Given this list of marker genes Itga2, Rbm25, Lpl, Znrf3, Tagap1, Cntfr, Vps13a, Plag1, Pip4p2, Spock3, Yaf2, Ccdc120, Zfp850, Tbx22, Neto1, Zbtb41, Syncrip, Zfp148, Extl2, Wtap, Cebpg, Nrbf2, Set, Strbp, Rasa2, Sh3rf1, Fhip1b, Cmtm8, Tmem196, Hopx, Rnf214, Itgb1, Lin9, Mef2d, Rnf144a, Srgap3, Rad21, Map7d2, Crybg3, Vkorc1l1, Skint9, A630023A22Rik, Wrap73, Slc4a7, Ppm1h, Epc2, Edil3, Gria3 (NCBI Gene Id 73036), Cstf3, Med14, Homer1, Cnbp, Rictor, Arl6ip6, Gm4884, Prickle1, Spry1, Cxcl16, Khdc4, Pira12 (paired-Ig-like receptor A12), Smo, Tab2, Ralgds, Gtf2b, Mrpl39, Dock11, Csmd2, Zfp36l2, Cacng5, Serpinb10, Sema3a, Gucy1a2, Lrrc7, Spag9, Rap1gap2, Lix1l, Zfp407, Lin52, Cacna1b, Ifit2, Zc3h12c, Tmem151a, Tcerg1l (transcription elongation regulator 1-like), Dmrta2, Fam76b, Stk24, Phrf1, Epb41l1, Tnfaip8, Irs1, Ano4, Epha7, Nectin3, Zfp30, Ttll7, Hoxd1, Kcnma1, Psd3, Milr1, Tubgcp5, Zfp608, Mtmr6, Myt1l, Rab11fip3, Clcn2, Eif5a2, Egln1, Marf1, Arid1b, Stard13, Prpf4b, Eml6, Alcam, Btbd3, Fosb, Srpk2, Gfod1, Fgd4, Asah1, Loxl3, Plxna2, Unk, Mex3c, Tada2b, Gabra1, Styx, Ctsc, Slc38a2, Cxcl5, Marchf7, Dleu7, Trhr, Golph3, B3galt2, Lrp8, Rgs4, Ube3c, Zfp704 (NCBI Gene Id 269407), Klf6, Nrf1, Elmod1, Adamts1, Ccdc68, Lztfl1, Itpr1, Aak1, Nxt2, U2surp, Xiap, Rab11b (NCBI Gene Id 320652), Arhgef7, Zfp451, 1700066M21Rik, Rev3l, Zfp521, Far1, Foxf2, Erf, Gm3604, Tbc1d22b, Gk, Golim4, Gm5114, Ankhd1, Eea1, Dlg2, Nefl, Fbxo34, Trim34a, Akap13, Zfp1008, Crebrf, Epha4, Ets1, Taok1 (TAO kinase 1), Dennd4a, Mex3b, Trhde, Cramp1, Prr12, Akap9, Olfml2b (olfactomedin-like 2B), Xpo7, Cask, Grsf1, Txlng, Hectd2, Arhgap29, Qrfprl, Pms1, Rnf38, Cul3, Ccnc, Zmym6, Fbxl17, Rab14, Gucy1b1, Rerg, Cilk1, Yy1, Ccar1, Arhgef33, Sh3gl3, Wdr43, Efnb2, Ssbp2, Usp42, Pde4dip, Runx2, Tshz3, Phf8, Mfsd1, Calu, Gpcpd1, Lrrc42, Cflar, Btg1 (BTG anti-proliferation factor 1), Fchsd2, Il1rap, Phf6, Schip1, Dip2b, Kmt2c, Mkrn2os, Arid4b, Adgrf5, Msx2, Lrp6, Hycc2, Zfp280d, Pcsk5, AI182371, Adgre4, Rsbn1, Fam210a, Ankrd1, Akain1, Tmc8, Herc6, Ccdc25, Mcu (mitochondrial calcium uniporter), Hmgxb4, Rnf4, Zwint, Zfp811, Rab7, Nr4a3 (NCBI Gene Id 18124), Il7, Heatr5b, Abcb1b, Fgf4, Dck, Pea15a, Mbd4, Anks1b, Arhgef10l, Eif4ebp1, Rb1cc1, Fli1, Zfyve16, Usp32, Zbtb44, Nek1, Tardbp, Dnttip2, Six6, Timp3, Otx2, Pmp22, Rgmb, Arl8a, Camsap2, Dcdc2a, Kbtbd7, Mapk1, Carmil1, Slc17a6, Pitx2, Mpzl1, Adamts17, Slc8a1, Lifr, Vcan, L1cam, Dnali1, Klhl14, Pum2, Kif2a, Tob1, Zbtb10, Nr3c2, Arfgef2, Ythdc2, Erg28, Pdik1l, Camk2d, Ndst3, Spred1, Zbtb11, Pira2, Fbxl5, Atad1, Bmper, Gpm6b, Usp25 (NCBI Gene Id 30940), Bdnf, Usp6nl, Serpinb9g, Evx2 (NCBI Gene Id 14029), Impg2, Csgalnact2, Chek2, Zrsr2, Sdcbp, Bdp1, Tmem215, Rsf1, Tceanc, Wdfy3, Zswim6, Sdad1, Tjp2 (NCBI Gene Id 226034), Sft2d3, Prr16, Tmtc2, Ddx10, Tmem68, Sfpq, Dlat, Cep135, Tm9sf3, Nfyb, Nom1, Med13, Dennd2b, Mrc1, Zmat1 (zinc finger, matrin type 1), Prkcd, Ptp4a3, Mphosph10, Rasef, Fbxo33, Col19a1, Nkrf, Rcn2 (NCBI Gene Id 27014), Ttc7, Dph6 (NCBI Gene Id 66632), Tnrc6c, Lamtor3, Spin1, Cdh9, Ino80d, Diaph2, Svil, Trim59, Septin9, Gm5592, Foxa1, St8sia4, Gm15881, Hhip, Zfp182, Lemd3, Itch, Rbfox1, Vps13d, Kif13a, Cfap20, Sh3gl2, Ddx21, Elovl5, Rad51d, Sox21, Ntrk2, Sim1, 1110059G10Rik, Myrf, Nlrp2 (NLR family, pyrin domain containing 2), Dync1li2 (dynein, cytoplasmic 1 light intermediate chain 2), Pafah1b1, Rngtt, Alg6, Grm5, Ppfia2, Rab11fip2, Nr1i2, Eif1ad (NCBI Gene Id 69860), Ckap2, Gata3, Zfp935, G2e3, Cav2, Sptbn1 (NCBI Gene Id 268394), Tagap, Mthfd1, Lats1, Glipr1l2, Hdac4, Clec12a, Casp8ap2 (caspase 8 associated protein 2), Akap6, Dcun1d4, Btaf1, Bmp3, Trpc1, Tmem41b, Bmp5, Mbnl2, Ptprr, Ptprb, Ube2b, Fgfr2, Tle1, Grpr, Nectin4, Hivep1, Ankrd13c, Tnfrsf11b, Cks2 (CDC28 protein kinase regulatory subunit 2), Map2, Sema4b (NCBI Gene Id 20352), Cd209a, Ppat, Fzd8, Mllt10, Zfp592, Otud4, Ino80, Rbm27, Pgm2l1, Kif21a, B3galt1, Kdm6a, Fut9, Herc1, Rtn1, Gch1, Glo1, Ank2, Ugt2a2, Gabra2, Tob2, Krt73, Plekhm3, Fech, Zdhhc21, Tgfbr3, Tasp1, Myo9a, Plppr5, Trim68, Kcna2, Syt13, Etv3, Naa20, Dusp10, Lhx8, Vps35, Kif3a, Cwc22, Tfg, Adam23, Scn2a (sodium channel, voltage-gated, type II, alpha), Bmpr2, Pcdh7, Arhgef11, Ndnf, Appl1, Dgkd, Ulk2, Dbx1, Rock2, Avl9, Jph1, Rab10, Uty, Lrp1b, Ubxn7, Marchf6, Mospd1, Ctla4 (NCBI Gene Id 12477), Apobec3, Tle4, Kmt2e, Pik3c2a, Osbpl8, Rif1, Necap1, Pcf11, Asxl1, Ppa2, Slc18a2, Sbf2, Ssb, Rnf111, Rai1, Ccser1, Kank1, Iqschfp, Fgl2, Nup35, Chrna1, Hip1, Kcne4, Hook3, Zbtb2, Tspan12, Topbp1, Mast4, Gpatch8, Eif4enif1 (NCBI Gene Id 77952, eukaryotic translation initiation factor 4E nuclear import factor 1), Ctdspl2, Araf, Casz1, Secisbp2l, Pfkfb3, Tada1, Arap2, Satb2, Cttnbp2, Myadm, Rgs17, Ugt2a1, Emc7, Ubqln2, Zic1, Spty2d1, Gopc (golgi associated PDZ and coiled-coil motif containing), Evx1, Calca, here is a description of the gene set: Mouse Gene Set: MIR_669D_2_3P_MIR_669L_3P from publication Chen Y, Wang X (PMID 31504780) studied in species Mus musculus Genes predicted to be targets of miRBase v22 microRNA mmu_miR_669d_2_3p, mmu_miR_669l_3p in miRDB v6.0 with MirTarget v4 prediction scores > 80 (high confidence targets).